The following is a description of a gene set: Abnormal circulating carboxylic acid concentration studied in species Homo sapiens Human Gene Set: HP_ABNORMAL_CIRCULATING_CARBOXYLIC_ACID_CONCENTRATION Any deviation from the normal concentration of a carboxylic acid in the blood circulation., and this is the list of marker genes: MT-ND3, ATP5F1A, CD320, AIFM1, OSTM1, NDUFV2, TMEM67, OTC, SLC6A18, DGUOK, BCKDHA, MTHFD1, SLC36A2, PRKCSH, VPS33B, ABCB11, HBB, ETFDH, NDUFS3, GPX1, NDUFA13, PCCB, UROS, COQ9, OAT, PDP1, IMPDH2, MDH1, ACAD8, SLC25A13, PET117 (NCBI Gene Id 100303755), SLC10A1, NDUFS8, GLDC, MICU1, KYNU, MICOS13, MMADHC, POMC, NDUFC2, GPHN, MED12, NDUFAF6, BOLA3, NHLRC2 (NHL repeat containing 2), GUCY2D, IRF5, ABCD3, ADK, PGM2L1, PRF1, NFE2L2, NDUFS6, PAX8 (paired box 8), SLC26A4 (solute carrier family 26 member 4), MYO5B, KLF1, TDO2, HPD, SEC63, ODC1, SLC35A2, NDUFA1, SLC25A15, SUCLG1, TNFSF15, FDFT1 (NCBI Gene Id 2222), SLCO1B1 (solute carrier organic anion transporter family member 1B1), SARDH, IFT56, MT-ND4, MMAB, SDHB, AP1B1, KIF23, BCAT2, SLC25A4, NADK2, COX6A2, PEX19, SKIC3, TWNK, RFX6, MTRR, NAGS, G6PD, WDR35, IARS1, ASNS, SPTA1, ABCC2, CASK, SLC7A7, EFL1, IDH2, COX5A, EHHADH, TRMU, ALDH7A1 (NCBI Gene Id 64414), TEFM, BCKDHB, ALDH5A1, COX10, ASPA, ATP5F1E, DUOX2, SCO1, MT-TW, IGF1, BCS1L, NOS3, SUGCT, MT-ND5, MCEE, MT-ATP8, PNPLA8, NDUFB10, FBP1, AKR1D1, PGK1, UPB1 (NCBI Gene Id 51733), COL7A1, HCFC1, SPIB, SLC52A1, MTTP, NR4A2, PPM1K, TG, PSPH, FAH, SLC2A2, CPOX, CBS, LIPT1, LBR, PKLR, NT5C3A, TNPO3, SLC17A5, ACAD9, DNAJC19, MAT1A, MT-TI, ZNF699, DTYMK, NDUFB3, ANK1, GCDH, SLC6A20, MTR, AASS, BCKDK, ATP5F1D, ACAT2, ETFB, GLYCTK, ATP5MK, SLC51B, FOCAD, HAL, ARG1, TMEM70, ASL, PDHA1, EPB42, ACADM, PFKM, BAAT, NDUFAF4, SLC6A19, NAA10, L2HGDH, KMT2D, EPB41, SLC19A1, NDUFS1, PNPLA6, CPT2, GYPC, PC, HS6ST2, IRF6, MT-ND6, SERAC1, CDAN1, NKX2-5, BLVRA, NDUFS4, TRMT10C, SLC25A20, ATP5F1B, LIG3, PEX2, MTO1, UBR1, ETFA, EIF2AK3, CTH, HSD3B7, NDUFB9, LIPT2, NDUFAF1, SLC4A1, SUCLA2, KIF12, TJP2, SPR, PTS, MRPL39 (mitochondrial ribosomal protein L39), MMP1, ALDOA, HMGCL (NCBI Gene Id 3155), GCSH, CCDC47, TANGO2, MIPEP, FOXRED1, GLS, GATA1 (GATA binding protein 1), MCCC1, NKX2-1, MRPS14, UBE2A, VPS50, LRP5, NDUFV1, QDPR, NDUFAF5, SLC34A1, ABCD4, COX16, MRPS2, NFU1, TSHB, TALDO1, LDHA, AMACR, ATPAF2, SLC2A1, PLAU, PIGA, RHCE (Rh blood group CcEe antigens), SBDS, PSAT1, KARS1, SLC51A, SLC35C1, GALT, DNM1L, PCBD1, TARS2, SPTBN1, PCK1, RHD, HSD17B10, MRM2, PHGDH, MT-TL1, PRODH, NDUFA6, APP, NUBPL, GSR, NDUFA2, MT-ATP6, IVD, MT-TV, ATP8B1, SLC22A5, ATP7B, TNFRSF11B, DZIP1L, ALDOB, GNMT, TIMMDC1, OTX2, ALDH18A1, MMUT, KCNN4, LYRM7, MMAA, PCCA, CHD8, TPO, GLRX5, TFAM, HK1, FARSB, GCH1, VIPAS39, UROC1, SLC25A26, ATAD1 (ATPase family AAA domain containing 1), IBA57 (iron-sulfur cluster assembly factor IBA57), COX8A, PIEZO1, MTHFR, SCO2 (synthesis of cytochrome C oxidase 2), DNAJC21, OPA1, PDHX, SLC6A3, UNC45A, SLC30A10, ASS1, MT-TP, NDUFS7, NDUFS2, DLD, HADHA, NGLY1, PEX26, MMEL1, NDUFAF3, ACSF3, NDUFB11, ALDH6A1, GAMT, LMBRD1, GATM, POLG, TSHR, PNPO, NDUFA11, INSR, SPTB, MPV17, RRM2B, CYP7B1, HMBS, ROBO1, TCN2, VARS2, IL12RB1, TYMP, PRDX1, SLC5A5, NR1H4, LONP1 (NCBI Gene Id 9361), HADH, PITRM1, MT-TK, GLUL, TCEAL1, COX6B1, GBA1, CA5A, SEMA7A, IYD, MPO, ALDH4A1, PAFAH1B1, LYN, FOXE1, MMACHC, TMEM126B, MT-ND2, ETHE1, SLCO1B3, FTCD, NDUFAF8 (NCBI Gene Id 284184), FBXL4, TAT, AHCY, DCDC2, ACADS, SC5D, MT-TE, CTNS, ACADVL (acyl-CoA dehydrogenase very long chain), MECP2, POU2AF1, AMT, MRPL3, MPC1, NDUFAF2, DUOXA2, MCCC2, PEX14, DMGDH, NFS1, UQCRC2, POLG2, RHAG, IL12A, USP53, CPS1, MT-ND1, FH, PKHD1, PAH, RNU4ATAC, ABCB4, UGT1A1, RACGAP1, MT-TF, OBSCN